Given this list of marker genes GDI2, PFKL, BNC1, ARF4, PSMC5, RPL18, DDOST, S100A8, EXOC7, ITGB4, HSD17B10, SELENOP, NTAN1, DOK1, SRSF1, CD82, HS3ST1, KRT19, ANXA7, SERPINE2, GSTM5, SCP2, GATA5, FGFBP1, LGALS9, UFD1, CALM2, HLA-B, AP2A2, CPE, CX3CL1, PURA, GNAI1, ATF2, CYP2J2, IER2, TKT, MYC, PSMC1 (NCBI Gene Id 5700), PIGF, VDAC1, TLE1, PA2G4, SEPHS2, BAX, PFN1, SLC12A1, CLNS1A, COPS5, OSTF1, CLCN3, PTHLH, PTPRM, UCP2, CD53, CASP3, YWHAQ, CCT3, ENPP1, XRN2, NOCT, PPP1CB, MXI1, TFAM, MAN1A1, CNIH1, ITIH2, DDX24, HMMR, TPD52, UBE2H, EPS15, FOXA2, CPT2, NFKBIA, ACADM, PLXNA2, PPFIBP2, BCAP31, STOM, RALY, NPEPPS, MRC1, AHCY, SEC23A, KRT15, EPS8 (NCBI Gene Id 2059), SOD1, IL1R1, EDN2, MMP13, ARHGDIB, DMBT1, PRKACB, FHL1, ABCD3, HMGA2, HELLS (NCBI Gene Id 55121), STAC, TM4SF1, SOS1, FXYD5 (FXYD domain containing ion transport regulator 5), STIP1, ROCK1, OAZ1, ACADL, YWHAZ, WT1, MAPK14, LORICRIN, LBP, H3-3A, PAM, PTPRR, AIP, SERPINB6, CDKN2A, CTNNB1, GPD1, TPM3, NHERF1, TRIM25, PRKG2, EGR1, SLC35A1, SLC22A18 (NCBI Gene Id 8042), ANXA11, MTHFD2, GSTP1, DDX19A (NCBI Gene Id 55308), RNF2, YWHAH, HCCS, SPRR1A, KLF3, FNTA, RAB18, CFTR, BTC, GSS, AQP8, PSME1, ZFP36L1, ANXA8L1, FOS, MRPL23, TCEA1, GJA1, CDH1, S100A13, GNA11, ECH1, DYNLT1, PPARG, SDF2, CD55, IL1RN, PDCD2, KLF4, CDKN1A, SDC4, GAS8, STK3, LGALS3, IVL, HNRNPH1, FOSL1, DBP, KCNAB1, ATP6V1A, ATP6V1E1, GJB4, TOP2A, TP53, TNNT2, PIGQ, CXCL6, SRP14, CYP3A4, HMBS, FKBP2, HAX1, TCEA3, SNAP23, PENK, UGT1A10, ATP5MC1, SEC22B, GNB5, AMD1, FDFT1, SLC3A2, PHYH, ATP5F1B, TMEM165, CAPZA2, CASP4, ABCB1, ALAD, POLR1D, TOB1, ELP5, EYA2, CBX1, SLC1A5, POLR2C, here is a description of the gene set: Polarized hepatocytes expressing hyperactive Ha-Ras adopt an invasive and metastatic phenotype in cooperation with transforming growth factor (TGF)-beta. This dramatic increase in malignancy is displayed by an epithelial to mesenchymal transition (EMT), which mimics the TGF-beta-mediated progression of human hepatocellular carcinomas. In culture, hepatocellular EMT occurs highly synchronously, facilitating the analysis of molecular events underlying the various stages of this process. Here, we show that in response to TGF-beta, phosphorylated Smads rapidly translocated into the nucleus and activated transcription of target genes such as E-cadherin repressors of the Snail superfamily, causing loss of cell adhesion. Within the TGF-beta superfamily of cytokines, TGF-beta1, -beta2 and -beta3 were specific for the induction of hepatocellular EMT. Expression profiling of EMT kinetics revealed 78 up- and 235 downregulated genes, which preferentially modulate metabolic activities, extracellular matrix composition, transcriptional activities and cell survival. Independent of the genetic background, platelet-derived growth factor (PDGF)-A ligand and both PDGF receptor subunits were highly elevated, together with autocrine secretion of bioactive PDGF. Interference with PDGF signalling by employing hepatocytes expressing the dominant-negative PDGF-alpha receptor revealed decreased TGF-beta-induced migration in vitro and efficient suppression of tumour growth in vivo. In conclusion, these results provide evidence for a crucial role of PDGF in TGF-beta-mediated tumour progression of hepatocytes and suggest PDGF as a target for therapeutic intervention in liver cancer. Human Gene Set: GOTZMANN_EPITHELIAL_TO_MESENCHYMAL_TRANSITION_DN Genes down-regulated in MMH-RT cells (hepatocytes displaying an invasive, metastatic phenotype) during epithelial to mesenchymal transition (EMT). from publication Gotzmann J, Fischer AN, Zojer M, Mikula M, Proell V, Huber H, Jechlinger M, Waerner T, Weith A, Beug H, Mikulits W (PMID 16607286) studied in species Mus musculus